The following is a description of a gene set: Mouse Gene Set: GOBP_LATE_ENDOSOME_TO_VACUOLE_TRANSPORT species: Mus musculus The directed movement of substances from late endosomes to the vacuole. In yeast, after transport to the prevacuolar compartment, endocytic content is delivered to the late endosome and on to the vacuole. This pathway is analogous to endosome to lysosome transport., and this is the list of marker genes: Vta1, Chmp3, Ptpn23, Tmem50a, Snf8, Chmp6, Chmp1b, Chmp2a, Chmp1a, Becn1, Chmp7, Vps36, Vps4b, Vps28, Leprotl1, Chmp4b, Tmem50b, Vps25, Vps4a, Chmp4c, Leprot, Chmp1b2, Becn2, Chmp2b, Stam, Chmp5, Pik3r4